The following is a description of a gene set: An abnormality of the soft palate. Human Gene Set: HP_ABNORMAL_SOFT_PALATE_MORPHOLOGY studied in species Homo sapiens Abnormal soft palate morphology, and this is the list of marker genes: EDN1, DDX3X, IQSEC2, RPL31, LARGE1, GLI2, USP9X, KCNN3, GJA5, MSX1, H4C5, FOXI3, RPL35A, NODAL, DLG3, MAD2L2, HYLS1, KIF14, RYR1, SMS, RLIM, GJA8, CRPPA, FKBP14, PPP1CB, RPL8, TGFBR2, TTN, SLC25A19, RPL35, EFEMP1, FANCC, KCNK9, RPS15A, TGIF1 (TGFB induced factor homeobox 1), ORC1, FGFR2, BCOR (NCBI Gene Id 57686), ORC4, BICRA, BIN1, COL11A1, RAD51C, CDC45, POLA1 (DNA polymerase alpha 1, catalytic subunit), PALB2, THOC6, COL4A1, PGM1, ERCC4, ZEB2, FKTN, RECQL4, FOXH1, PI4KA, SEMA3E, COL11A2, POMK, SATB2, TBX5, FANCI, FLNA, POMT2, IFT140, CHD7, SMAD4, XRCC2, SMPD4, PIGL, KCNH1, EYA1, PIEZO2 (NCBI Gene Id 63896), GRHL3, RIC1, RXYLT1, TBCE, CDT1, BRCA1, INTS11, FLII, AMMECR1, BUB1, DLG1, HNRNPK, SEC23A, DGCR8, PIGV, MYL11, TAF4, MED12, RFX7, DVL1, RPS24, FANCD2, RPL9, FGFR3, ARHGEF38, FANCA, SON, COL2A1, RPL18, ZIC2, PIGW, SNRPB, STAC3, AEBP1, DHCR7, FANCL, EIF4A3, GLI3, SMAD2, PDGFRA, KMT2C, B4GAT1, RFWD3, NXN, TBX22, HAAO, SPTBN1, SERPING1, PIGY, RPS26, TWIST2, RPL27, SETD5, B3GALNT2, SEPTIN9, SIX1, IGBP1, FGFR1, SHH, BMP4, POGZ, NONO, DLK1, COBLL1, RPL11, RPS28, ORC6, RPL26, DDX59 (DEAD-box helicase 59), IPO8, RNU4ATAC, SNRPN, MEG3, ROR2, ALG9, RNU4-2, TUBB6, FANCB, CDON, PGAP3, RPS17, ZPR1, POLR3A, ADA2, MSX2, FGF10, TGFB2, TCOF1, POMT1, GATA1, TP63, DAG1, RPS27, CRIPTO (cripto, EGF-CFC family member), NEK1, RPS7, TBX1, TGFB3, RAD21, SLC2A10, TGDS, KIF7, KCTD1, BRCA2, ARHGAP29, TGFBR1, DLX4, DHCR24, FANCE, RPL5, STAG2, SMC1A, DGCR6 (DiGeorge syndrome critical region gene 6), PIGO (phosphatidylinositol glycan anchor biosynthesis class O), SHMT2, PLCH1, KAT6B, ERI1, FANCM, PRR12, SMAD3, GMNN, SPEG, RPS19, SIAH1, DGCR2, SELENOI, SMARCD1, FANCG, PTDSS1, RPS23, ZSWIM6, CUL3, ARMC9, NECTIN1, METTL23, KDM6A, RTL1, RPL15, XYLT1, UBE2T, SUPT16H, MAP3K7, CDH1, SF3B4, STIL, DISP1, PLCB4, FKRP, FILIP1, PGAP2, FBXO11, SLX4, B9D2, TCTN3, GAS1, IRF6, RAD51, BRIP1, SCNM1, ALG3, GNB2, WDR35, TSR2, RAI1, FTO, ASPH, HEATR3, AMER1, MYMX, KDM6B, DYRK1A, RPS29, SIX3, ATP6V1B2, DEAF1, SMCHD1, PGAP1, B4GALT7, RPS10, ESS2, GNAI3, UBB, TWIST1, CDC6, KMT2D, DLL1, SKIC3, POMGNT1, FGF8, BGN, PTCH1, FANCF, TXNL4A, POMGNT2, CDH11, CHD4, RPS20, HYAL1, SLC39A13